The following is a description of a gene set: Mouse Gene Set: GOBP_GLUTAMATE_RECEPTOR_SIGNALING_PATHWAY studied in species Mus musculus The series of molecular signals initiated by the binding of glutamate to its receptor on the surface of a target cell, and ending with the regulation of a downstream cellular process, e.g. transcription., and this is the list of marker genes: Gria4, Trpm1, Ptk2b (NCBI Gene Id 211703), Nrxn1, Grin1 (glutamate receptor, ionotropic, NMDA1 (zeta 1)), Grm1, Kcnb1, Frrs1l, Homer1, Gnaq, App, Sstr1, Kalrn, Grm4, Homer3, Dlg4, Grik3, Gria3, Grm3, Tiam1, Necab2, Plcb1, Fyn, Grid2ip, Grik2, Prnp, Homer2, Cx3cl1, Grm7, Gria1, Grik1, Grin2c, Ncstn, Grm8, Gria2, Plp1, Cdk5r1, Fmr1, Grin2b, Cln3, Gna11, Cpeb4, Grm5, Atp1a3, Grik5, Ephb2, Adrb2, Grm2, Grin3a (NCBI Gene Id 83489), Camk2a, Grm6, Nlgn3, Slc1a1, Shank3, Mef2c, Grin2d (glutamate receptor, ionotropic, NMDA2D (epsilon 4)), Grin3b, Gm527, Unc13a, Grin2a